The following is a description of a gene set: Human Gene Set: HP_APLASIA_HYPOPLASIA_OF_THE_PROXIMAL_PHALANGES_OF_THE_HAND studied in species Homo sapiens Aplasia/Hypoplasia of the proximal phalanges of the hand, and this is the list of marker genes: TBX5, BMPR1B, VAC14 (VAC14 component of PIKFYVE complex), FIG4, COL2A1, IHH, GDF5, MTOR, XRCC2, KIF15, FGFR3, FANCD2, SHH, TRIO, LMBR1